The following is a description of a gene set: Reactome Pathway: Formation of WDR5-containing histone-modifying complexes WDR5 is a component of six mammalian histone methyltransferase KMT2 complexes: Mixed Lineage Leukemia (MLL) 1-4, SET1A, and SET1B. All KMT2 complexes consist of a histone methyltransferase (KMT2A, KMT2B, KMT2C, KMT2D, SETD1A, or SETD1B, respectively) and the WRAD subcomplex composed of WDR5, RBBP5, ASH2L, and DPY30. The WRAD complex regulates the enzymatic activity of histone methyltransferases and enables their recruitment to chromatin. Additional transcription cofactors associate with each KMT2 histone methyltransferase complex, enabling their functional diversification. For a detailed overview, please refer to Cho et al. 2007, Song and Kingston 2008, Takahashi et al. 2011, Couture and Skiniotis 2013, van Nuland et al. 2013, Klonou et al. 2021.<br><br>The KMT2 complexes are evolutionarily conserved. While a single SET1/COMPASS complex is present in yeast, three distinct complexes are present in Drosophila: trithorax (Trx), trithorax-related (Trr), and Set1. In mammals, due to gene duplication, two Trx-like complexes (one with KMT2A and another with KMT2B as the catalytic subunit), as well as two Trr-like complexes (one with KMT2C and another with KMT2D as the catalytic subunit), and two Set1-like complexes (one with SETD1A and another with SETD1B as the catalytic subunit) are formed. For review, please refer to Rao and Dou 2015.<br><br>All KMT2 complexes methylate lysine K5 of histone H3 (K4 in mature histone H3 peptides, as the initiator methionine is removed), which is associated with transcriptional activation. Different KMT2 complexes preferentially monomethylate, dimethylate, or trimethylate H3K4, depending on the presence of accessory subunits, transcriptional co-factors, and posttranslational modifications. The catalytic activity of KMT2 complexes may differ between endogenous complexes and complexes reconstituted in vitro by mammalian proteins expressed and produced in bacterial or insect cells. The KMT2A and KMT2B complexes preferentially methylate H3K4 at a limited number of target gene promoters, while KMT2C and KMT2D complexes preferentially methylate H3K4 at a limited number of target gene enhancers. SETD1A and SETD1B complexes are responsible for the bulk of cellular H3K4 methylation and show less target specificity. For overview, please refer to Patel et al. 2009, Wang et al. 2009, Rao and Dou 2015.<br><br>In both Drosophila and vertebrates, KMT2 complexes control the expression of evolutionarily conserved Hox genes which serve as master regulators of embryonic patterning.<br><br>Germline mutations in human KMT2 complexes are the underlying cause of several chromatinopathies. Germline loss-of-function (LOF) mutations in KMT2A cause Weideman-Steiner syndrome, a rare autosomal-dominant disorder characterized by intellectual disability, developmental delay, pre- and post-natal growth delay, hypertrichosis, short stature, hypotonia, distinctive facial features, skeletal abnormalities, feeding problems and behavioral difficulties. Germline LOF mutations in KMT2B cause dystonia-28 (DYT28) and intellectual developmental, autosomal dominant disorder-68 (MRD68). DYT28 is an autosomal dominant neurologic disorder characterized by onset of progressive dystonia in the first decade of life, while MRD68 is an autosomal dominant disorder characterized by developmental delay/intellectual disability, microcephaly, poor growth, feeding difficulties, and dysmorphic features. Germline LOF mutations in KMT2C cause Kleefstra syndrome-2 (KLEFS2), an autosomal dominant neurodevelopmental disorder characterized by delayed psychomotor development, variable intellectual disability, and mild dysmorphic features. Germline LOF mutations in KMT2D cause Kabuki syndrome 1, a congenital mental retardation syndrome with postnatal dwarfism, a facial dysmorphism and skeletal abnormalities. Germline LOF mutations in SETD1A cause early-onset epilepsy with or without developmental delay (EPEDD), an autosomal dominant neurologic disorder, and neurodevelopmental disorder with speech impairment and dysmorphic facies (NEDSID). Germline LOF mutations in SETD1B cause intellectual developmental disorder with seizures and language delay (IDDSELD).<br><br>Somatic mutations in KMT2 genes contribute to cancer development. They were first discovered in Mixed Lineage Leukemia (MLL), characterized by chromosomal translocations that involve the KMT2A gene locus on chromosome 11 (chromosomal band 11q23) and result in the expression of fusion proteins with oncogenic properties. Besides gene fusions, other types of KMT2A mutations are also present in blood cancers (most frequently in high-grade B-cell lymphoma, T-cell lymphoblastic leukemia, and acute myeloid leukemia) and solid tumors (most often reported in lung adenocarcinoma, colon adenocarcinoma, and bladder urothelial carcinoma). Somatic cancer mutations in other KMT2 genes (KMT2B, KMT2C, KMT2D, SETD1A and SETD1B) are less characterized but most frequently affect the catalytic SET domain and show different distributions between different cancer types. For review, please refer to Rao and Dou 2015, Castiglioni et al. 2022. Several anti-cancer therapeutics are being developed that affect the association of KMT2 enzymes with components of the WRAD complex, in particular WDR5.<br><br>WDR5 is also a component of three histone acetyltransferase complexes, GCN5-ATAC, PCAF-ATAC, and MOF/KAT8-NSL. part of: Epigenetic regulation by WDR5-containing histone modifying complexes species: Homo sapiens, and this is the list of marker genes: KANSL2, ZZZ3, PHF20L1, KAT2A, KMT2B, CXXC1, TASP1, AKAP8L, DPY30, KAT14, PHF20, KMT2A (lysine methyltransferase 2A), BOD1, HCFC1, KANSL1, OGT, TADA3, WDR82, HCFC2, KAT8, PAXIP1 (NCBI Gene Id 22976), BOD1L1, KMT2C, KDM6A, MEN1, DR1, KANSL3, NCOA6, MBIP, SGF29 (NCBI Gene Id 112869), RBBP5, MCRS1 (microspherule protein 1), SETD1B, PAGR1, ASH2L, KAT2B, KMT2D, TADA2A, SETD1A, YEATS2, PSIP1, WDR5